Given this list of marker genes STN1, PCNA, POLD2, PRIM2, TERF2IP, POLA2, POT1, PRIM1, RFC1, TERF2, CHTF8, TINF2, RFC5, POLD1, POLD3, POLD4, DSCC1, ACD, TERF1 (NCBI Gene Id 7013), RFC4, RFC3, CHTF18, RFC2, TEN1, CTC1, POLA1, here is a description of the gene set: studied in species Homo sapiens Human Gene Set: REACTOME_POLYMERASE_SWITCHING_ON_THE_C_STRAND_OF_THE_TELOMERE Polymerase switching on the C-strand of the telomere